Given this list of marker genes USP38, CORO1A, PPIH, PAK2, IARS2, PRRC1, HIVEP3, TDRD3, MBTPS2, CFAP20, SEC11C, PHACTR2, SLC30A6, ATP7A, ABCB7, TRPV2, CEP170, MEF2A (NCBI Gene Id 4205), HACL1, ACSL4, VDAC3, RAB2A, FHIP2B, RBM33, MRPS2, RUVBL1, BPNT1, DBT, BCL2L11, ETAA1, YOD1, AP5S1, LDAF1, UFSP2 (UFM1 specific peptidase 2), ATP6AP2, PTGR2, AGPAT5, ATP6V1E1, ZDHHC20, CWC25, RNF144A, RINT1, DAXX, TRAK1, FARP2, ATP6V1A, STOML2, GARS1, EIF3C, PNPLA8, INTS12, TLE3, MTOR, CIPC, VPS37C, DLAT, TUBA4A, SUCLA2, FBXL20, PTPRA, TXNDC5, PHACTR4, ARL6IP6, VPS41, LYSMD3, ADPRM, WDR62, ZNF672, TGFBRAP1, BRD7, RELCH, UNKL, CPT2, FXR1, RNF169, LMO2, CTNNBL1, RWDD2B, ATP6V1D, SEMA4A, EIF3F, HBP1, MED13, CNTD1, PALS2, DDX39A (DExD-box helicase 39A), BRK1, ING2, PRKCD, ACOT11, IL15, MKNK1, TKT, TSN, TMEM205, RNF2, ZBTB5, UBXN4, CCNG2, AP3M1, DIAPH2, GRAMD4, SYK, DIP2A, HSF2, ZCRB1, CEP78, MMGT1, GOLM1, SCAMP1, MTF2, ZFHX3, GMEB1, KMT5A, ENOPH1, LYL1, CDC14B, NAA15, STX17, ZNF655, TCHH, TYK2, TMCC1, PIEZO1, WIPF1, ITM2B, SLC19A2, RREB1, SCAI, RHOQ, PEX11A, CNOT2, MXI1, HSPA14, CAMSAP2 (NCBI Gene Id 23271), RAF1, CERK, VPS13B, PSMA3, NDUFB9, MFSD9 (major facilitator superfamily domain containing 9), MINDY2, NPAT (nuclear protein, coactivator of histone transcription), H3C4, TMED3, TENT4A, BNIP3L, FAIM, ZDHHC7, HACD2, MCTP1, AMPD3, SPOP, LRRC45 (NCBI Gene Id 201255), CRAMP1, SCARB1 (scavenger receptor class B member 1), KLHL15, TAPT1, ZC2HC1A, SIRT3, PHF10, PCIF1, ALAS1, PGAP1 (NCBI Gene Id 80055), SGK1, UPF3B, TTPAL, API5, MFSD8, POLR3F (NCBI Gene Id 115527), RBM41, USP46, PRKD3, PPP1R15B, NECAP1, FICD, STX6, SPN, CAMK1D, PINK1, MAP3K20, HDAC5, SNX18, ALG1, RALGAPA2, CEP44, URB2, IFIT2, PHKB, RABGAP1L, HMBOX1, RAPGEF2, CHMP3, TRIO, MROH1, NNT, ARHGEF6, HMG20A, KLHL20, HMBS, here is a description of the gene set: studied in species Homo sapiens from publication Kerkar SP, Goldszmid RS, Muranski P, Chinnasamy D, Yu Z, Reger RN, Leonardi AJ, Morgan RA, Wang E, Marincola FM, Trinchieri G, Rosenberg SA, Restifo NP (PMID 22056381) Genes up-regulated in B16 melanoma at day 3 of adoptive transfer treatment: mock versus therapy. Myeloid-derived cells comprising the tumor stroma represent a heterogeneous population of cells critical to the structure, function and growth of established cancers. We have recently found that engineering tumor-specific CD8+ T cells to secrete IL-12 (IL-12TD) can lead to striking improvements in T-cell activity against established melanomas in murine models. Surprisingly, IL-12-dependent enhancement of CD8+ T-cell anti-tumor function did not occur through direct ligation of receptors on lymphocytes or NK cells. Instead, IL-12 sensitized host bone marrow-derived tumor-stromal cells, partly through interferon-gamma, to indirectly enhance the effects of adoptively-transferred T cells. Direct presentation of antigen by tumor was not necessary, but MHC class I expression on endogenous cells was essential for IL-12 mediated anti-tumor enhancements. Upon successful treatment with IL-12TD cells, we observed the selective elimination of tumor-infiltrating CD11b+ F4/80+ macrophages, CD11b+/ClassII+/CD11c+ dendritic cells and CD11b+/Ly6C+/Ly6G- but not CD11b+/Ly6C+/Ly6G+ myeloid-derived suppressor cells within regressing lesions. These results are consistent with a model whereby IL-12 triggers the maturation of myeloid-derived cells into competent antigen cross-presenting cells. Licensed recognition of these antigens by effector T cells may in turn trigger the collapse of the tumor stroma and aid in the regression of large vascularized lesions. Human Gene Set: GSE29164_CD8_TCELL_VS_CD8_TCELL_AND_IL12_TREATED_MELANOMA_DAY3_UP